The following is a description of a gene set: This event has been computationally inferred from an event that has been demonstrated in another species.<p>The inference is based on the homology mapping from PANTHER. Briefly, reactions for which all involved PhysicalEntities (in input, output and catalyst) have a mapped orthologue/paralogue (for complexes at least 75% of components must have a mapping) are inferred to the other species. species: Mus musculus part of: Intrinsic Pathway for Apoptosis Reactome Pathway: Activation of BH3-only proteins electronically inferred by orthology from the curated human pathway, and this is the list of marker genes: Bad, Ywhah, Dynll1, Mapk8, Ppp3r1, Ppp3cc, Sfn, Pmaip1, Ywhae